Given this list of marker genes TNXB, FAXDC2, SLC26A4, SYNDIG1, CASQ2, MEOX2, CD36, AKAP12, TLE4, GFRA2, ALDH1B1, STARD13, GLDC, PLN, PLCH1, TBC1D4, SLC1A1 (NCBI Gene Id 6505), APOD, TOB1, FOSB, OGN, AOC3 (amine oxidase copper containing 3), IRS1, GNAI1, BMP2, CCL14, TFPI, ALDH1A2, RPS6KA5, SLC16A2, CXCL12, NDRG4, PRKACB, ALDH7A1, SETBP1, LDB2, IGF2 (insulin like growth factor 2), MT1H, HHEX, ALDH6A1, FGFR2, GNA14, FGL2, EDN3, ARHGEF28, CCL21, ALDH1A1, LRP1B, ALDH2, WASF3, SGCD, HSPA12A, MEIS2, RELN, EMCN (NCBI Gene Id 51705), MDM1 (NCBI Gene Id 56890), SSPOP, RERGL, IER2, CLDN5, FCGBP, PRPSAP1, SFRP1, CRYAB, FBLN1, EPB41L4B, BCL2, ID4, GDF10, SH3BGR, ZFP36L2, MT1X, ADD3, CPNE3, ENPP1, LRP2, EGR1, DCN, NUP62CL, ZNF302 (zinc finger protein 302), SH3BP5, FOXJ1, COPZ2, FEZ1, PDE10A, GCAT, FXYD1, SALL2 (NCBI Gene Id 6297), SNTA1, HLF, LIMK2, CLMN, FOLR1, MYCN, ELMO1, P2RY14, CRABP1, ITM2A (NCBI Gene Id 9452), PCLO, RYR2, EML1, TAL1, NRN1, SORD, LIPG, CYBRD1, FMO2, EPHA3, KCNK2, CLCNKA, TSPAN7, DNASE1L3, FAAH (fatty acid amide hydrolase), JUN, ASPH, PRKX, GNG11, HBA1, LAMA2 (laminin subunit alpha 2), IFT25, CLCNKB, PAX8, MT1F (NCBI Gene Id 4494), HSD17B3, ADH1B, SLC25A15, FGF13, CCN1, SRPX, RGS16, GPC3, DLG2 (discs large MAGUK scaffold protein 2), PRKY, MT1E, GRB14, CDC42EP2, MYOC, SLC4A4, MTMR4, FBLN5, ARL4A, FXYD6, ZFPM2 (NCBI Gene Id 56958), CITED2, ASGR1, SPTBN1, IQGAP2, ID3, PRKCQ, NUCB2, IPCEF1, GHR, TPO, RAP1GAP, TSC22D3, GSTM3, LTF, EYA2, MT1G, PLA2R1, ACKR3 (atypical chemokine receptor 3), TEK, ACSF2, DIO2, DPP6, ZDHHC11, ROR2, MATN2, ITIH5, TNFSF10, CSRP2, CDH16, EGR2, TNFAIP8, TNFRSF11B, NCAM1, LIFR, FABP5, CTH, FMOD, CHRDL1, ITPR1, SLC38A1, HBG2, RGS17, NPR1, HGD, WFS1, LMO2, SEMA3D, MAGED4, TSPOAP1, AKR1C1 (aldo-keto reductase family 1 member C1), SDC2, TGFBR3, FOS, SLC14A1, GAS1, DNAJB4, RASSF9, TRAPPC6A, WWOX, MT1L, FMO1, FHL1, NEB, DPT, PHYH, CPQ, LPAR1, PLA2G7, GPER1, HBB, TLE1, KCNAB1, FLRT2, AOX1, KIT (NCBI Gene Id 5086), EPB41L3, SYNE1, ADH1A, CA4, UCHL5, ESRRG, SORBS2, PROM1, COL9A3, PTN, DIO1 (iodothyronine deiodinase 1), SYNM, MPPED2, MGP, ALDH4A1, here is a description of the gene set: Genes down-regulated in papillary thyroid carcinoma (PTC) compared to normal tissue. The purpose of this paper is to correlate the molecular phenotype of papillary thyroid carcinoma (PTC) to their biological pathology. We hybridized 26 PTC on microarrays and showed that nearly 44% of the transcriptome was regulated in these tumors. We then combined our data set with two published PTC microarray studies to produce a platform- and study-independent list of PTC-associated genes. We further confirmed the mRNA regulation of genes from this list by quantitative reverse transcription-PCR. Analysis of this list with statistical tools led to several conclusions: (1) there is a change in cell population with an increased expression of genes involved in the immune response, reflecting lymphocyte infiltration in the tumor compared to the normal tissue. (2) The c-jun N-terminal kinase pathway is activated by overexpression of its components. (3) The activation of ERKK1/2 by genetic alterations is supplemented by activation of the epidermal growth factor but not of the insulin-like growth factor signaling pathway. (4) There is a downregulation of immediate early genes. (5) We observed an overexpression of many proteases in accordance with tumor remodeling, and suggested a probable role of S100 proteins and annexin A2 in this process. (6) Numerous overexpressed genes favor the hypothesis of a collective migration mode of tumor cells. Human Gene Set: DELYS_THYROID_CANCER_DN from publication Delys L, Detours V, Franc B, Thomas G, Bogdanova T, Tronko M, Libert F, Dumont JE, Maenhaut C (PMID 17621275) species: Homo sapiens